Given this list of marker genes BMI1, FOXD1, CDKN1C, TULP3, KIF2C, CDK1, TCF12, CBFA2T2, EGR1, JUNB, TERF1, EIF2AK2, NFATC4, FOXG1, MAZ, POU4F1, KDM5A, CUL4A, ATF2, RFX2, CORO1A, BUB1 (BUB1 mitotic checkpoint serine/threonine kinase), SATB1, ST18, ING2, GSPT1, NPAS1, CEBPZ, SNAPC5, KIF23, SOX9, WEE1, CCNB2, DEK, SMARCD2, NDC80, CTCF, MYCN, ATF3, PAX6, NFKB1, MCM6, MYC, MEF2D, SNW1, NME2, SIX6, ZNF267, PRH2, CITED2 (Cbp/p300 interacting transactivator with Glu/Asp rich carboxy-terminal domain 2), KPNA2 (karyopherin subunit alpha 2), ADNP2, INSM1, KDM4A, SMARCA2, TSC22D2, NSD2, HOXA7, CEBPG, ETV5, YY1, NDN, WDHD1 (NCBI Gene Id 11169), CDK3 (cyclin dependent kinase 3), E2F1, KHDRBS1, HSF2, TAF7, CDK6, MYBL2, SMAD5, DNMT1, CXCL2, ZBTB43, MNDA, HDAC2, ACTL6A, KNTC1, SMARCA5, EWSR1 (NCBI Gene Id 2130), RAD21, TAF11, ZNF43, KIF22, TOX4, CBX4 (NCBI Gene Id 8535), CCNE1, MAD2L1, DLX5, HMGB2, SIX3, ZNF646, SOX4, MCM3, FOS, BIRC5, E2F3, SSX4, TOX, ZNF195, ZNF124, GFI1, CCNA1, PMS1, GAS7, KLF11, BRPF1, ZBTB24, TLE1, EGR2, ZNF324, FOXM1, NOLC1, HMGB1, PTGER4, PPP5C, LANCL1, MID1, ZBTB18, PHB2, ZNF136, GABPB1 (GA binding protein transcription factor subunit beta 1), ZNF254, CXCL1, TBRG4, HIF1A, ZNF16, ELAVL2, PTTG1, MYT1, UBE2C, HOXC6, NEK4, TFDP1 (NCBI Gene Id 7027), KMT2A, CCNB1, BRD1, EZH2, CDC7, JUN, HOXC11, ILF3, CDC25A, ID4, ATF4, GTF2I, CXCR4, YBX1, CDC25B, MAFG, TFAP2A, ETS2, MEIS1, MTA1, SSRP1 (NCBI Gene Id 6749), CCNA2, NCAPD2, FOSL1, TAF5, DDX11, CHRM3, CDK4, CCNG2, ZNF211, TXNL4A, RCC1, RBBP8, TAF4, PLK1, LHX2, ELF4, SMC2, CCL17, GTF2F2, here is a description of the gene set: Genes in the cancer module 197. Human Gene Set: MODULE_197 species: Homo sapiens